Given this list of marker genes MIR204, MYOCD, MEF2C, MIR1-1, EFNB2, MIR499A, TGFB1, WNT3A, ARRB2, KAT2A, BMP4, here is a description of the gene set: studied in species Homo sapiens Any process that activates or increases the frequency, rate or extent of cardiac muscle cell differentiation. Human Gene Set: GOBP_POSITIVE_REGULATION_OF_CARDIAC_MUSCLE_CELL_DIFFERENTIATION